The following is a description of a gene set: species: Mus musculus Mouse Gene Set: GOBP_REGULATION_OF_LIPOPHAGY Any process that modulates the frequency, rate or extent of lipophagy., and this is the list of marker genes: Sptlc2, Sesn2, Adrb2, Sptlc1, Htt